The following is a description of a gene set: studied in species Homo sapiens Genes up-regulated in comparison of Th17 cells versus naive CD4 T cells. Human Gene Set: GSE14308_TH17_VS_NAIVE_CD4_TCELL_UP from publication Wei G, Wei L, Zhu J, Zang C, Hu-Li J, Yao Z, Cui K, Kanno Y, Roh TY, Watford WT, Schones DE, Peng W, Sun HW, Paul WE, O'Shea JJ, Zhao K (PMID 19144320) Multipotential naïve CD4+ T cells differentiate into distinct lineages including T helper 1 (Th1), Th2, Th17, and inducible T regulatory (iTreg) cells. The remarkable diversity of CD4+ T cells begs the question whether the observed changes reflect terminal differentiation with heritable epigenetic modifications or plasticity in T cell responses. We generated genome-wide histone H3 lysine 4 (H3K4) and lysine 27 (H3K27) trimethylation maps in naïve, Th1, Th2, Th17, iTreg, and natural (n)Treg cells. We found that although modifications of signature cytokine genes (Ifng, Il4, and Il17) partially conform to the expectation of lineage commitment, critical transcription factors such as Tbx21 exhibit a broad spectrum of epigenetic states, consistent with our demonstration of T-bet and IFN-gamma induction in nTreg cells. Our data suggest an epigenetic mechanism underlying the specificity and plasticity of effector and regulatory T cells and also provide a framework for understanding complexity of CD4+ T helper cell differentiation., and this is the list of marker genes: TBC1D31, REEP3, MAPK9, DEPP1, SLC36A4, FBXO27, CNIH1 (NCBI Gene Id 10175), ZC2HC1A (NCBI Gene Id 51101), NEDD8, RANBP9, STAB1, MRPL55, PSMA1, NDE1, GRIK4, CYP11A1, CEMIP2, LANCL2, GPM6B, VBP1, GAPDH, YME1L1, COX17, CD79B, MDH1, GSTM4, BLVRB, LIMD2, ZMAT2, HJURP, KIF20B, SSRP1, IKZF4, KIFAP3, GLIPR1L1, HSPA4L, STAG3, GNPNAT1, RAD51D, RAD18, RRAGC, ZBTB44, QKI, IPO7, CFAP68 (cilia and flagella associated protein 68), PKD2, TAF13, DDIAS, QRICH1, B3GALT5, SLC39A1, P2RY10, CHMP7, ANLN, LPL, LRBA, TST, ARMCX4, PPP1R16A, HTRA2, PTRH1, ACBD6, LRRC20 (leucine rich repeat containing 20), GINS4, CPNE3, PLCXD1, MATCAP2, PSMD12, CFAP418, ALOX5AP, HMOX1, MND1, PIWIL2, MCTP1, ALG2, TESC, COQ9, NDST1, POLE, IFT46, BET1, TRIM45, PML, PIK3AP1, MOSPD2, TUBG2, MVD, FLOT2, CCDC34, DHDH, MANF, CRNKL1, LAMTOR1, TPD52L2, CISD3, PWWP2B, EXTL1, AGBL5, NENF, FNTA, ABCC4, MRPL35, CLDN12, PXMP2, MCAM, NIFK, PSPH, DENND11, REEP1, PFKM (phosphofructokinase, muscle), UCHL5, FOCAD, SRSF1, GCSH, SSR3, CDC14B, ARHGEF10, COX19, HLA-DQA1, TUBG1, SSU72, SLC6A13, MYO5A, MFSD2A, TMEM181, LEO1, ACACA, ACTR10 (actin related protein 10), NEK8, PEX2, TSPAN6, RCL1, ZWILCH, AKTIP, ACTG2, DPY19L4, CSRNP1, GMFG, FYTTD1, MICAL1, ZFAND4, TSHZ1, NDUFA13, ZBTB7A, NKIRAS2, SEPTIN9, ADAM12 (NCBI Gene Id 8038), MNAT1, BMPR2, JHY, TRIM24, LRP10, PPP6R1, CNOT11, ATXN1L, NSMF (NCBI Gene Id 349336), HDAC1, ALDH18A1, DYNC2I1, ZSWIM7, ATP10A, RIDA, SRSF10, NSDHL, RILPL1, NDC80, GTF2IRD1, ORMDL2, MSMO1, PDCD6IP, CDK2AP1, EIF3F, HOMEZ, EYA2, RAD51B, C11orf54, MAP3K10, GMPR, RPN2, AP3B1, ITFG1, ABT1, CCDC47, AP2B1, PDZD11 (PDZ domain containing 11), CALU, CRYZ, PPP2R5C, SLCO3A1, GNGT2, EML2, PDE6D, RPAP2 (RNA polymerase II associated protein 2), DIO3OS, RPS6KA5, EIF2B1, COL18A1, ERG28, USP47, KIF14